The following is a description of a gene set: Mouse Gene Set: GOCC_CHITOSOME species: Mus musculus An intracellular membrane-bounded particle found in fungi and containing chitin synthase; it synthesizes chitin microfibrils. Chitin synthase activity exists in chitosomes and they are proposed to act as a reservoir for regulated transport of chitin synthase enzymes to the division septum., and this is the list of marker genes: Rab7, Mfsd12 (major facilitator superfamily domain containing 12), Canx, Bace2, Tyrp1, Gpr143, Atp7a, Dct, Dtnbp1, Ctns, Rab32, Oca2, Gpnmb, Tyr, Slc45a2, Sytl2, Th, Rab38, Mreg, Tpcn2, Abcb6, Pmel